Given this list of marker genes GYPE, GPBP1, MED4, TRIP4, CCNT1, PNPT1, POLR2C, LINC00470, C2orf69, UHRF2, ZNF148, SLC40A1, CKAP5, DET1, YPEL1, AKR1E2, RBM20, SAGE1, JPX, NOC3L, BUB1, WDR11, HSD17B12, ENSG00000232884, CPOX, SLC35E2A, H3C6, RBM48P1, RNF216P1 (ring finger protein 216 pseudogene 1), KDM3B, EPCIP-AS1, ZNF138, ISLR2, OSGIN2, LRBA, HTR5A, TXNL1, TAFA2, PCOLCE, CRPPA, PDE4C, ANKRD17, BHLHE40, MAPK6, ANKRD45, LRRD1, OR4K17, BCAP29, SP5, ARHGEF12, VTA1, AFG2B, LINC03021, ZFPM2, RNA5SP60, MAN2A2, ENSG00000215156, ENSG00000253986, ENSG00000227706, ZSCAN16-AS1, PXK, RNU6-169P, SECISBP2L, MEF2C-AS1, ALKBH3, ADGRV1, BRD7P4, USP15, ZRANB2-DT, ZC3H13, ARHGAP11B-DT, FRG1CP, ENOSF1, RPRD1A, CDAN1, RGS5, MRPS33, MNAT1, ENSG00000232732, LINC00240, STK38L, UBR3, MIR7-3, LAMB1, CRYZL1, NXT2, ALG10, CDCA2, ZRANB2, TTN-AS1, ARID3A, BRPF1, ENSG00000232995, PSMD6, SPRYD7, CALM2, NKAPP1, C11orf68, GPR19, AHI1, GUSBP18, TCERG1, TRAM1, FLJ46284 (NCBI Gene Id 441369), ANXA2R, KCTD9, MSANTD4, CPB2-AS1, GFM1, RPS18P5 (ribosomal protein S18 pseudogene 5), PCOLCE-AS1, LINC00431, KLRC4, ENSG00000199470, DENND1B, GYPB, ZNF391, RNU6-925P, RBM17, DOCK7, TTC5, TERB2, VN1R95P, SPOCD1, RESF1, LINC01347, SNX11, CENPF, EIF4E, CHGB, NDUFA5P3, GSTCD, DENND4A, PRKD1, MFAP3L (microfibril associated protein 3 like), ATL2, NR2F2-AS1, FAM98B, SEC22B, KLRC4-KLRK1, PDE7A (phosphodiesterase 7A), MIR7-3HG, FNBP1P1, CCNA2, NOC2LP1, UBE4A, DRAP1, EIF5A2, PABPC1P10, LUC7L2, LINC02928, CENPE, LRP4-AS1 (NCBI Gene Id 100507401), RCHY1, HUS1, GBE1, ANP32BP3, SAMSN1-AS1, SMYD3, COX16, ENSG00000187951, NGDN, VN1R81P, CT45A10, FER, LACTB2-AS1, PCLAF, FMC1 (formation of mitochondrial complex V assembly factor 1 homolog), SRD5A3-AS1, SMIM8, NUF2, CRPPA-AS1, LINC01234, LINC01191, CA1, CENPC, PDE7A-DT, RNF216, RAB11A, H2AC14, RARRES1, SCG3, WDR11-DT, MRPS27, GLRA1, NFIA, SCAF4, SLC25A15 (solute carrier family 25 member 15), DIAPH1, CT45A1, RMND5A, AGAP4, ZNF268, RN7SKP192, SEPTIN14P12, PAXBP1, MIS18BP1 (NCBI Gene Id 55320), SAMSN1, MS4A6A, MTERF1, NFE2, PLAC1, CSTPP1 (NCBI Gene Id 79096), SNRPD1, PTCD2, COMMD2, RBM45, CCDC152, FRA10AC1, SYT14, SGO2, GPR6, ZNF221, PPIG, ATR, GTF3C3, INTS12, OR52A5, STAM2, FAM133B, here is a description of the gene set: Human Gene Set: CHAMP1_TARGET_GENES studied in species Homo sapiens from publication Yevshin I, Sharipov R, Kolmykov S, Kondrakhin Y, Kolpakov F (PMID 30445619) Genes containing one or more binding sites for (CHAMP1) in their promoter regions (TSS -1000,+100 bp) as identified by GTRD version 20.06 ChIP-seq harmonization.